The following is a description of a gene set: studied in species Mus musculus Mouse Gene Set: CUI_T_CELL_GD_IFNB_RESPONSE_DN Cytokines mediate cell-cell communication in the immune system and represent important therapeutic targets. A myriad of studies have highlighted their central role in immune function, yet we lack a global view of the cellular responses of each immune cell type to each cytokine. To address this gap, the authors created the Immune Dictionary, a compendium of single-cell transcriptomic profiles of more than 17 immune cell types in response to each of 86 cytokines (>1,400 cytokine-cell type combinations) in mouse lymph nodes in vivo. A cytokine-centric view of the dictionary revealed that most cytokines induce highly cell-type-specific responses. For example, the inflammatory cytokine interleukin-1β induces distinct gene programmes in almost every cell type. A cell-type-centric view of the dictionary identified more than 66 cytokine-driven cellular polarization states across immune cell types, including previously uncharacterized states such as an interleukin-18-induced polyfunctional natural killer cell state. Genes negatively differentially expressed in cell type: γδ T cell upon treatment with cytokine: IFN-β in mouse lymph nodes in vivo. from publication Cui A, Huang T, Li S, Ma A, Pérez JL, Sander C, Keskin DB, Wu CJ, Fraenkel E, Hacohen N (PMID 38057668), and this is the list of marker genes: Cenpx, Tcf7, Rp9, Fxyd5, Vav1, Cd52, Cd7, Fosl2, Nsd1, Tcf12, S100a13, Ccdc88c, Ier2, Selplg, AB124611, Tbc1d10c, Arhgdib, Bnip3l, Myh9, Slc25a4, Cotl1, Slc25a3, Stk17b, Cxcr4, Hmgb1, Ets1, Ccl5, Srsf5, Ppp1r15a, Ddx5, Gimap6, Laptm5, Pabpc1, Itpkb (inositol 1,4,5-trisphosphate 3-kinase B), Crip1, Entrep3, Hook3, Hadh, Vasp, Lcp1, Fos, Btg2, Emp3, Tacc1, Sema4a, H2az1, Klrd1, S100a10, Ctsd, Ahnak, Hexim1, Gpx1, Cdk2ap2, Ralbp1, Klf3, Zfp36l2, Sh3bgrl3, Ftl1, Slc38a1, Arl5c, Snapc5, H2aj, Rnaseh2c, Rac2, Macf1, Thy1, Tesc, Chd3, Pfn1, S1pr1, Ifngr1, Add3, Klf2, Eef2, Sfpq, Tubb5, Mindy2, Junb, Gimap3, Actg1, Adgre5, Dusp1, Malt1, Map4k4, Wdr1, Qpct, Mplkip, Adcy7, Ankrd44, Gmfg, Myl6, Tle5, Zc3h13, Fam78a, Fkbp3, Acp5, Cd3g, Cd3d, Park7